The following is a description of a gene set: Mouse Gene Set: REACTOME_C_TYPE_LECTIN_RECEPTORS_CLRS C-type lectin receptors (CLRs) species: Mus musculus, and this is the list of marker genes: Rps6ka5, Syk, Psmb7, Calm2, Psmd7, Psmd12, Ube2d2a, Psmc4, Malt1, Fbxw11, Psmb4, Calm1, Psmb6, Nfkb1, Tab2, Nfkb2, Cd209a, Bcl10 (B cell leukemia/lymphoma 10), Psma4, Hras, Ube2v1, Ube2n, Card11, Cul1, Lyn, Ubc, Nfatc3, Tab3 (TGF-beta activated kinase 1/MAP3K7 binding protein 3), Psma5, Cdc34, Rela, Ikbkb, Prkacb, Psmd8, Prkaca, Pycard, Chuk, Ube2m, Uba52, Clec4n, Adrm1, Map3k7, Psma1, Card9, Nfatc1 (NCBI Gene Id 72364), Psmc6, Psma6, Ubb (NCBI Gene Id 22187), Psmc2, Nfkbia, Ppp3cb, Psmd14, Raf1, Ube2d1, Clec4d, Traf6, Psmd11, Kras, Map3k14, Skp1 (NCBI Gene Id 76591), Nfatc2, Psmc1, Psmc3, Psmd1, Ppp3r1, Pak2, Psma2, Casp8, Calm3, Tab1, Ep300, Psmd2, Relb, Pak1, Rps27a, Psmb2, Psma3, Psmb5, Pak3, Psma7, Psmd13, Src, Psmc5, Uba3, Fyn, Il1b, Plcg2, Ppp3ca, Prkcd, Uba52rt, Psmb1, Pdpk1, Fcer1g, Psmd3, Icam2, Psmb3, Ikbkg, Psmd6, Clec4e